Given this list of marker genes TBX3, MIR19B1, WNT3A, TENM4, SOX17, ACVR1, MESP1, ITGB1, POU5F1, WT1, NKX2-5, TBX18, ISL1, TBX5, here is a description of the gene set: species: Homo sapiens The commitment of cells to specific cardiac cell fates and their capacity to differentiate into cardiac cells. Cardiac cells are cells that comprise the organ which pumps blood through the circulatory system. Human Gene Set: GOBP_CARDIAC_CELL_FATE_COMMITMENT